Given this list of marker genes WDR37, STEAP2, FGD3, IDH2, DNAJA2, HMCES, MYBPHL, TMEM35A, PLCXD3, PCMTD1, PLXNA3, MAK16, FCGR1A, PHF6, APOBEC2, TCIRG1, GUCD1, SAA1, LRCH3, MSRA, MAPKAPK5, KLHL41, ITGA10, LGI4, SLC25A28, RHOU, TNF, XPO5, ZBED4, DDHD1 (NCBI Gene Id 80821), HS3ST4, RGL2, VGF, TPRA1, P3H1, MAP3K3, RNF145, USP31, MGAT4A, NCOA1, RMDN3, MRTFA, SORT1, C1orf52, DEAF1, PIGP (NCBI Gene Id 53821), ABI3, MMS19, CSNK2A1, ADIPOR2, ANGEL2, FAM241A, ASB4, STX6, FAM86B2 (NCBI Gene Id 653333), LPAR6, NELFA, PI4KA, INSR, PLEKHS1, CNTRL, MKNK1, PTTG1, RARG, ARL14, TMCC3, HES6, TRIR, FBXO38, SETD1A, ACADM, VPS13B, SMOC2, ZMYND8, F8A1, MAP3K2, REXO4, MARVELD1, SFT2D2, ORMDL1, SAP30L, PSME2 (proteasome activator subunit 2), TCOF1, ZNF394, FBXO46, KCNAB2, ZIC4, FRAT1, DNAJC8, BICRA, ADAMTS18, ZMYM5, CTNND1, SLC12A1, SLC24A4, SPO11, DHX58, ZNF157, NXPE3, PHAF1, CIC, DGKH, ARSK, RBM48, HOXD3, ST6GALNAC1, SLC4A1AP, NRP2, MYBPC3, ANTXR2, SLCO3A1 (solute carrier organic anion transporter family member 3A1), SBNO1, DDX5, UBALD2, REL, CHIC1, FMNL3 (formin like 3), RGN, NCOA3, HLTF, DDX55, ZNF623, YTHDC1, SPACA4, PPP6C, NAP1L4, GPD2, TRRAP, ZNF598, AREL1, SFSWAP, TMEM114, RPLP2, RBBP5 (NCBI Gene Id 5929), DENND3, APC, DLG3, VPS16, CEBPZ, CSE1L, ZNF322, ANKRD54, HSPD1, ZZEF1, ABHD1, LSP1, MPPED1, BET1L, CCN5, CREBZF, BANK1 (B cell scaffold protein with ankyrin repeats 1), TCHP, MTERF1, USP6NL, CCM2 (CCM2 scaffold protein), MRPL38, DNMBP, ATPAF1, C9, STAT5A, MBP, ELMOD2, LYST, CLK3, CD247, PARP9, ENO3, RAB14, PIWIL1, FAM13B, STAG2, TCEAL1, ZDHHC14, MRM1, ESR1, ZZZ3, TBX5, TRIAP1, COL11A2, DNAJB14, PIR, KDM1A, ANGPTL1, DDX6, DYNC2H1, NPPA, BCKDHB, CCL28, ZNF507, NUAK1, VSIR (NCBI Gene Id 64115), GIT2 (NCBI Gene Id 9815), RIGI, LPIN2, SEC11A, MBTPS1 (membrane bound transcription factor peptidase, site 1), MOB3A, FBXW4, SLC5A10, C2orf68, here is a description of the gene set: studied in species Homo sapiens from publication Wei G, Wei L, Zhu J, Zang C, Hu-Li J, Yao Z, Cui K, Kanno Y, Roh TY, Watford WT, Schones DE, Peng W, Sun HW, Paul WE, O'Shea JJ, Zhao K (PMID 19144320) Genes down-regulated in comparison of Th2 cells versus naive CD4 T cells. Human Gene Set: GSE14308_TH2_VS_NAIVE_CD4_TCELL_DN Multipotential naïve CD4+ T cells differentiate into distinct lineages including T helper 1 (Th1), Th2, Th17, and inducible T regulatory (iTreg) cells. The remarkable diversity of CD4+ T cells begs the question whether the observed changes reflect terminal differentiation with heritable epigenetic modifications or plasticity in T cell responses. We generated genome-wide histone H3 lysine 4 (H3K4) and lysine 27 (H3K27) trimethylation maps in naïve, Th1, Th2, Th17, iTreg, and natural (n)Treg cells. We found that although modifications of signature cytokine genes (Ifng, Il4, and Il17) partially conform to the expectation of lineage commitment, critical transcription factors such as Tbx21 exhibit a broad spectrum of epigenetic states, consistent with our demonstration of T-bet and IFN-gamma induction in nTreg cells. Our data suggest an epigenetic mechanism underlying the specificity and plasticity of effector and regulatory T cells and also provide a framework for understanding complexity of CD4+ T helper cell differentiation.